Given this list of marker genes PLXNA3, PLXNA1, NRP2, SEMA3E, NDNF, NRP1, here is a description of the gene set: The directional movement of a gonadotrophin-releasing hormone producing neuron from the nasal placode to the hypothalamus. species: Homo sapiens Human Gene Set: GOBP_GONADOTROPHIN_RELEASING_HORMONE_NEURONAL_MIGRATION_TO_THE_HYPOTHALAMUS